Given this list of marker genes COPS2, B3GNTL1, WFDC13, GAR1, SRGAP3, CUL1, SH2B3, EPHA6, TNFSF11, DMRT1, ZNF529, BTBD7, ZNFX1, WT1, AS3MT, SMARCC1, PURA, ZNF605, CHD2, KAT7, NT5E, TNKS, AAK1, C17orf67, DNASE2B, MRPS6, SEPHS1, SNAPC5, LARP1B, ARID4B, BRAP, POLR3B, ARSG, TXNDC16, KRTAP11-1, TMEM59, DARS1, RAB2A, TRH, UBE2D3, LEPROT, HERC4, PTPRT, KCNAB1, PTPN2, KDM4A, MEDAG, VPS53, MEF2C, MAPT, EPB41L3, PDCD6IP, TTC7A, DOP1A, WIPF2, ELF5, ZNF449, PROX1 (prospero homeobox 1), BIRC2 (baculoviral IAP repeat containing 2), CDC14B, PBX1, RTL4, NR4A2 (NCBI Gene Id 4929), FIGN, ASIC2, GNA13, BNIP2, MPC1L, FRYL, CDKN2C, SULT4A1, CTNNB1, PRKD3, here is a description of the gene set: species: Homo sapiens from publication Chen Y, Wang X (PMID 31504780) Human Gene Set: MIR657 Genes predicted to be targets of miRBase v22 microRNA hsa-miR-657 in miRDB v6.0 with MirTarget v4 prediction scores > 80 (high confidence targets).